The following is a description of a gene set: studied in species Homo sapiens Human Gene Set: MIR3945 Genes predicted to be targets of miRBase v22 microRNA hsa-miR-3945 in miRDB v6.0 with MirTarget v4 prediction scores > 80 (high confidence targets). from publication Chen Y, Wang X (PMID 31504780), and this is the list of marker genes: TRIM2, RSKR, C1orf74, RNFT2, GHR, MYOF, MIGA1, ARPP19, PCDH9, SPATS2, GTF3C2, TRMT13 (NCBI Gene Id 54618), BTBD1, PCDHB3, KIRREL2, KBTBD2, CCDC178, PIK3R5, SMIM43, DTD1, CACNB4, IL26, FAM72A, FAR2, FNDC3B, CLPB, CCBE1, GABRG2, ZNF93, TADA1, KCNC4, FAM72D, COPS7B, CADPS, SANBR, XPO1, ZNF230, RIC8B, FAM72B, HNRNPR, BIRC6